Given this list of marker genes Atp7a, Nfe2l1, Mt3, Prnp, Aqp2, Aqp1, Snca, Atp7b, Hsf1, Mt2, Map1lc3a, Mt4, Becn1, Bace1, Cyp1a1, Nfe2l2, Daxx, Mt1, here is a description of the gene set: Mouse Gene Set: GOBP_CELLULAR_RESPONSE_TO_COPPER_ION species: Mus musculus Any process that results in a change in state or activity of a cell (in terms of movement, secretion, enzyme production, gene expression, etc.) as a result of a copper ion stimulus.